Given this list of marker genes TNF, STAT6, IKBKE, BAX, XRCC2, TNFAIP3, CASP2, STAT1, IKBKB, CDKN1A, CDK2AP1, CASP10, STAT5B, here is a description of the gene set: species: Homo sapiens Genes down-regulated in K562 cells (bone marrow) after treatment with dasatinib or imatinib. Human Gene Set: NUNODA_RESPONSE_TO_DASATINIB_IMATINIB_DN from publication Nunoda K, Tauchi T, Takaku T, Okabe S, Akahane D, Sashida G, Ohyashiki JH, Ohyashiki K (PMID 17213809) Dasatinib is an ATP-competitive, multi-targeted SRC and ABL kinase inhibitor that can bind BCR-ABL in both the active and inactive conformations. From a clinical standpoint, dasatinib is particularly attractive because it has been shown to induce hematologic and cytogenetic responses in imatinib-resistant chronic myeloid leukemia patients. The fact because the combination of imatinib and dasatinib shows the additive/synergistic growth inhibition on wild-type p210 BCR-ABL-expressing cells, we reasoned that these ABL kinase inhibitors might induce the different molecular pathways. To address this question, we used DNA microarrays to identify genes whose transcription was altered by imatinib and dasatinib. K562 cells were cultured with imatinib or dasatinib for 16 h, and gene expression data were obtained from three independent microarray hybridizations. Almost all of the imatinib- and dasatinib-responsive genes appeared to be similarly increased or decreased in K562 cells; however, small subsets of genes were identified as selectively altered expression by either imatinib or dasatinib. The distinct genes that are selectively modulated by dasatinib are cyclin-dependent kinase 2 (CDK2) and CDK8, which had a maximal reduction of <5-fold in microarray screen. To assess the functional importance of dasatinib regulated genes, we used RNA interference to determine whether reduction of CDK2 and CDK8 affected the growth inhibition. K562 and TF-1BCR-ABL cells, pretreated with CDK2 or CDK8 small interfering RNA, showed additive growth inhibition with imatinib, but not with dasatinib. These findings demonstrate that the additive/synergistic growth inhibition by imatinib and dasatinib may be mediated in part by CDK2 and CDK8.